Given this list of marker genes Aldh7a1, Bche, Enpp6, Chka, Dmgdh, Chdh, Ache, here is a description of the gene set: Mouse Gene Set: GOBP_CHOLINE_METABOLIC_PROCESS The chemical reactions and pathways involving choline (2-hydroxyethyltrimethylammonium), an amino alcohol that occurs widely in living organisms as a constituent of certain types of phospholipids and in the neurotransmitter acetylcholine. species: Mus musculus